The following is a description of a gene set: Human Gene Set: REACTOME_ABACAVIR_TRANSMEMBRANE_TRANSPORT Abacavir transmembrane transport studied in species Homo sapiens, and this is the list of marker genes: ABCB1, SLC22A3, SLC22A1, ABCG2, SLC22A2